Given this list of marker genes SLC29A1, ITPA, NME1, ADK, ADA, SLC29A3, SLC28A2, SLC28A3, PNP, NT5C2, NME2, here is a description of the gene set: Human Gene Set: REACTOME_RIBAVIRIN_ADME studied in species Homo sapiens Ribavirin ADME